Given this list of marker genes Card10, Cd2ap, Traf3ip2, Nop53, Uaca, Tsc2, Gper1 (G protein-coupled estrogen receptor 1), Ppp3ca, Cdkn1a, Heatr3, Il33, Stk3, Plk1, Akap1, Hdac3, Mark3, Dcp1b, Taf8, Mavs, Pom121l2, Eif2ak3, Sun2, Col1a1, Mepce, Sumo1, Lmnb2, Trim40, Npm1, Tnpo2, Tor1a, Trim29 (tripartite motif-containing 29), Nf2, Prkd1, Cav2, Syne1, Kcnq2, Sox9, Glul, Tek, Fbxo4, Rassf5, Gckr, Appl2, Tor1aip2, Ngfr, Syk, Prkcd, Nup133, Fam76b, Nuak2, Kpna3, Phb2, Appl1, Pom121, Nup153, Akt1, Tmem98, Cse1l, Jak2, Bard1 (NCBI Gene Id 12021), Tardbp, Ints13, Hm629797, Nup62, Nup50l (NCBI Gene Id 78482), Cry2, Txnip, Pola2, Tbrg1, Ifng, Hspa8, Dnajb6, Six2, Bag3, Srsf1, Nr4a1, Mapk1, Dtx3l, Src, Apod, Mcrs1, Lilrb4b, Prickle1, Nup54, Xbp1, Ipo4 (NCBI Gene Id 75751), Eif4enif1, Cacnb4, Adar, Snupn, Lamtor5, Notch1, Nolc1, Dmap1, Nutf2-ps1 (nuclear transport factor 2, pseudogene 1), Chp1, Rrs1, Cnep1r1, Htt, Ptpn22, Nup58, Nup88, Xpa, Tmem201, Dclk3, Jak1, Rap1gds1, Lmnb1, Zic1, Gbp4, Hcls1, Glis2 (NCBI Gene Id 83396), Mtor, Nup107, Pik3r2, Sin3a, Agt, Hyal2, Elavl1, Zc3h12a, Kpna4, Six3, Stk11, Pttg1ip2, Ahr, Ipo11, Smo, Ing1, Bmpr1a, Abca7, Rbm22, Cdk5rap3, Larp7-ps, 1700009N14Rik, Sirt6, Fam53c, Efcab7, Pin1rt1, Tesk1 (NCBI Gene Id 21754), Akap5, Mapk14, Abra, Trim28, Bmpr2, Nup62cl, Lzts2, Tcf7l2, Sqstm1, Arl2bp, Agtr2, Psen1, Skp1, Taf3, Ipo13, Il6, Otud7b, Hnf4a, Ywhae, Bmp4, Nr5a1, Nol8, Nup50, Cdk1, Mdm2, Nup214, Ipo5, Pkia, Lats1, Sirt1, Utp25, Rpf2, Prkcq, Xpo1, Zbtb16 (zinc finger and BTB domain containing 16), E2f3, Fam53b, Wrap53, Calr (calreticulin), Cd36, Wwtr1, Bmp2, Nvl, Park7, Tor1aip1, Kpnb1, Msx1, Flna (NCBI Gene Id 245705), Ddx5, Sesn2, Yap1, Sprn, Tfrc, Rangap1, Kpna6, Tnpo3, Ep300, Sun1, Hdgf, Fgf9, Paf1, Phip, Kpna7, Wrn, Fam53a, Ins1, Fermt2, Grk2, Trp53, Ywhab, Tyk2, Parp9, Akirin2 (akirin 2), Ranbp6, Ipo7, Morc3, Dclk2, Rab23, Hhex, Six4, Edn1, Lats2 (NCBI Gene Id 50523), Spg11, Tnpo1, Tmco6, Ufm1, Fermt1, Zpr1, Pygo1, App, Chp2, Dyrk1a, Angpt1, Shh, Pkig, Nos3, Cfl1, Bmal1, Pttg1ip, Sumo3, Ins2, Ctnna1, Nutf2, Hnrnpu, Larp7, Ppp3cb, Pik3r1, Pml, Rasl2-9, F2, Limk2, Lrrk2, Ipo8, Lilrb4a, Mmp12, Ppp3r1, Cabp1 (NCBI Gene Id 29867), Lmna, Ubr5, Ipo9, Kpna2rt, Pikfyve, Txn1, Dclk1, Trim8, Atp13a2, Stat3, Mdfic, Gsk3b, Ran, Osbpl8, Kpna2, Nutf2-ps2 (nuclear transport factor 2, pseudogene 2), Dvl1, Pin1, Pinx1, Cwh43, Cldn18, Atf2 (NCBI Gene Id 97033), Agap3, Nfkbia, Ctdnep1, Hsp90ab1, Irs1, Six1, Tert, Parp1, Mamdc4 (NCBI Gene Id 637857), Rpain, Bbs4, Cdkn2a, Tgfb2, Tor1b, Arl2 (ADP-ribosylation factor-like 2), Lep, Cdh1, Nup155, Drd1, Stk4, Sec13, Gli3, Hsp90aa1, Ormdl3, Ciz1, Ywhaz (tyrosine 3-monooxygenase/tryptophan 5-monooxygenase activation protein, zeta polypeptide), Tpr, Ei24, Ranbp2, Nfatc3, Hnrnpm, Hikeshi, Sp100, Zbtb7a, Ect2, Ptgs2, Rrp7a, Cdkl5, Pgr, Jup, Nup98, Ptpn5, Supt7l, Nmd3, Kcnq3, Nup85, Topors, Tgfb1, Epm2a, Med1, Nup93, Fyn, Nf1, Tnfrsf1a, Crebbp, Tmem147, Bcl3, Ilrun, Nup188, Nup35, Mfhas1, Rpl11, Maged1, Brca1, Polr1a, Cdk5, Ogt (O-linked N-acetylglucosamine (GlcNAc) transferase (UDP-N-acetylglucosamine:polypeptide-N-acetylglucosaminyl transferase)), Kpna1, Plrg1, here is a description of the gene set: Mouse Gene Set: GOBP_PROTEIN_LOCALIZATION_TO_NUCLEUS studied in species Mus musculus A process in which a protein transports or maintains the localization of another protein to the nucleus.